The following is a description of a gene set: species: Homo sapiens Any process that activates or increases the frequency, rate or extent of alcohol biosynthetic process. Human Gene Set: GOBP_POSITIVE_REGULATION_OF_ALCOHOL_BIOSYNTHETIC_PROCESS, and this is the list of marker genes: P2RY6, MIR96, FGF1, SCAP, PTH, MBTPS2, ADCYAP1R1, ABCG1, PRKACA, ABCG4, CD244, SNCA, MIR182, DAB2, GNAI1, NTSR1, P2RY1, WNT4 (NCBI Gene Id 54361), SREBF1 (NCBI Gene Id 6720, sterol regulatory element binding transcription factor 1), KPNB1, PRKAA1, QKI, MAPK1, BMP6, SREBF2, LHCGR, PAQR3, GPER1, AVPR1B, PTH1R, CYP7A1